Given this list of marker genes RIPK1, DGCR8, TRUB1, TGFB1 (NCBI Gene Id 7040), BMP4, here is a description of the gene set: Any process that activates or increases the frequency, rate or extent of microRNA processing. studied in species Homo sapiens Human Gene Set: GOBP_POSITIVE_REGULATION_OF_MIRNA_PROCESSING